Given this list of marker genes PSG9, DNAJC7, MRPS15 (NCBI Gene Id 64960), TOPORS, B2M, PLRG1, AURKA (NCBI Gene Id 8465, aurora kinase A), BST2, SNRPF-DT, KRTCAP2, WASL, UBR4, ATP5ME, TMEM192, SRFBP1, PIK3CB, ZDHHC5, SLC4A1AP, MIX23, NOPCHAP1, DDX20, RRN3, OPTN, EXOC6, DIABLO, GADD45A, DYNC1LI2, EVL, MGST3, CYP2U1 (NCBI Gene Id 113612), KBTBD4, CCDC83, PPM1D, PDK3, BBX, DUSP16, AHRR (aryl hydrocarbon receptor repressor), TYW5, SLC7A2, SIPA1L2, CCT7, AIMP2, CRB3, FUT8, CSGALNACT2, OCLN, HAPSTR1 (HUWE1 associated protein modifying stress responses), UBQLN1, PAK2, SUGT1, FXR1, SCFD1 (sec1 family domain containing 1), PSAP, ACBD3, FAF2, VAT1, THUMPD3, ATP6V1H, AKAP9, DYNC1H1, KLF8, F12, EIF2B4, TMEM199, PPFIA1, TDG, RBM26, NRDE2, ATP6V0E1, H4C8, PDAP1, EIF4G3, CPSF2, MRPS21 (NCBI Gene Id 64954), TGS1, HMMR, PLEKHB2, TRNP1, MKLN1, FDX1, RDX, DDX60 (DExD/H-box helicase 60), OCIAD1, LYSMD2, LONRF1, MRPL57, KIAA2013, USP47, EIF3A, KALRN, PHF11, CLTA, ZNF622, GPKOW, KATNBL1, DDX46, MTMR2, MTIF2, KAT5, FUNDC1 (NCBI Gene Id 139341), RB1CC1, BAZ2B, DKC1, RNASEL, PMP22, PAPSS2, CDR2, RERG, C17orf49, NSD3, NUFIP2, FHL2, JPT2, LIN7A, ZNF24, U2AF1, SPRYD7, DDX27, EXOC1, GANAB, INPP4B, MRPS28, IQGAP1, MEAF6, RNFT1, RPL23, HOXD8, PLEKHA1, SYNPO2, KCNQ3, GPATCH2, AP3B1, EIF5B, SLC26A11, TBC1D25, MACC1, SNRPA1, RASSF8, MBD1, FBXO28, HACL1 (NCBI Gene Id 26061), MRPS31, HYCC2, DUSP23, FKBP7, CGN, TBC1D7, SAMD9, PHF6, CCDC127, UBR5, TEFM, CHMP4A, SAP30BP, MAPK6, USP37, RNF7, COBLL1, VIRMA, LRRC41, MGAT5B, NSUN4, SMIM14, SRP68, TMEM64, H1-2, TMEM178B, HS6ST3, BAG3 (NCBI Gene Id 9531), PDE3A (NCBI Gene Id 8080), SAR1A, LCA5L, SH3GLB1, GSTCD, JUN, TRMT10A, FBXO3, TMOD3, RICTOR, ZNF445, CWC27, ATAD2B, TARDBP, ATP11C, BZW1, LYRM2, PRMT5, RBM22, GGACT, NUP88, HMGCS1, WDR41, SLF2, C9orf85, TNFRSF18, GOLPH3-DT, PURB, LINC00582, MAPK1IP1L, PFDN6, PSMC5, IRGQ, CHMP1B, FBLIM1, PSMD5, NRBP1, ACTA2 (actin alpha 2, smooth muscle), RAB18, MAD2L1BP, EIF3D, DLST, RBM15, GGNBP2, SLC3A2, MED6, SAMHD1, MPZL3, ATAD1, BCAS2, AATF, CPEB2, S1PR1, ZNFX1, BACE1, RNF6, CTNND1, ZNF341, MYH14, TIGAR, EXOC4, SYTL2, ARFGEF2, OCLNP1, UBA6, ICA1L, WAC-AS1, CDC37L1, MATCAP2, NGDN, RABGEF1, UTP4, USP28, PSG6, ITCH, GPR87 (NCBI Gene Id 53836), CASK, XIAP, NBR1, PAM, ERCC4, PTS, NCOA7, LINC02716, GAPDHP77, LARS1, FEZ2, MTIF3 (mitochondrial translational initiation factor 3), PDZD8, CDC42, DTNA, TRAV23DV6, TTC17, NAA20, ATP6AP1, RDH11, USP8, CASC3, WAPL, RNF181, SPTBN1, HSPB8, DMD, CLPTM1, RPF1, SNX6 (sorting nexin 6), ABCF2, SRP72, CAPZA2, DTX3L, SNX4, ATP6V1C1, LURAP1L, GPATCH4, KNOP1, IRF9, COG5, INSR, CLCF1, TUBD1, IFITM3, TBC1D9 (NCBI Gene Id 23158), ATXN1-AS1, MYLIP, ACSL3, NOL7, ATG4D, GATA3-AS1, SRA1, RETREG1, SNX22, DUSP3, ZNF407, PCGF6, HOOK2, HEATR6, POLB, DGCR8, NEAT1, KMT2A, DAGLB, GPRC5A, CCDC15, PRPF40A, STX12, SUN1, KAT14, GULP1, GATA2, CCDC137, SPART, TRIP12, RBM25, EXOC6B, ZC3H7A, WDR6, RAB14, COG6, EHMT1, ZFAND2A, NFKBIZ, DAPP1, FBXW11, IFIH1, RPS17P5, ZFR, RPL35A, GTF3C3, TMTC2, SRGAP1, RGS22, SMAP2, RC3H2, HLA-B, RUFY2, ZNF568, ELP2, ACTR2, EPC1, NECAB1, BCAP29, CHURC1, OSTM1, TOP1, ARCN1, AFF4, PIP5K1A, MED10, NDUFAF2, RAB11FIP1, PTPRK, LXN, EXOC3, here is a description of the gene set: The nuclear LIM-only protein 4 (LMO4) is upregulated in breast cancer, especially estrogen receptor-negative tumors, and its overexpression in mice leads to hyperplasia and tumor formation. Here, we show that deletion of LMO4 in the mammary glands of mice leads to impaired lobuloalveolar development due to decreased epithelial cell proliferation. With the goal of discovering potential LMO4-target genes, we also developed a conditional expression system in MCF-7 cells for both LMO4 and a dominant negative (DN) form of its co-regulator, cofactor of LIM domains (Clim/Ldb/Nli). We then used DNA microarrays to identify genes responsive to LMO4 and DN-Clim upregulation. One of the genes common to both data sets was bone morphogenic protein 7 (BMP7), whose expression is also significantly correlated with LMO4 transcript levels in a large dataset of human breast cancers, suggesting that BMP7 is a bona fide target gene of LMO4 in breast cancer. Inhibition of BMP7 partially blocks the effects of LMO4 on apoptosis, indicating that BMP7 mediates at least some functions of LMO4. Gene transfer studies show that LMO4 regulates the BMP7 promoter, and chromatin immunoprecipitation studies show that LMO4 and its cofactor Clim2 are recruited to the BMP7 promoter. Furthermore, we demonstrate that HDAC2 recruitment to the BMP7 promoter is inhibited by upregulation of LMO4 and that HDAC2 knockdown upregulates the promoter. These studies suggest a novel mechanism of action for LMO4: LMO4, Clim2 and HDAC2 are part of a transcriptional complex, and increased LMO4 levels can disrupt the complex, leading to decreased HDAC2 recruitment and increased promoter activity. Genes down-regulated in MCF7 cells (breast cancer) engineered to conditionally express LMO4 by a Tet Off system. studied in species Homo sapiens Human Gene Set: WANG_LMO4_TARGETS_DN from publication Wang N, Lin KK, Lu Z, Lam KS, Newton R, Xu X, Yu Z, Gill GN, Andersen B (PMID 17452977)